The following is a description of a gene set: studied in species Homo sapiens Shortening of all distal phalanges of the fingers Human Gene Set: HP_SHORTENING_OF_ALL_DISTAL_PHALANGES_OF_THE_FINGERS Hypoplasia of all of the distal phalanx of finger., and this is the list of marker genes: GLI3, PIGV, POR, PIGL, MGP, PGAP3, PIGO, PHF6, PIGW, VPS35L, PGAP2, PIGY, ALG6, BRF1